Given this list of marker genes SLC31A2, PTGES, FAM171B, LYZ, SDCBP, UGCG, TES, KIF2A, SGK1, PALLD, TGOLN2, RHOB, ARL4C, MT1B, ALCAM, BMP2K, DNAJC10, RAB14, GRAMD1A, PNMA1, CTNNAL1, SERF2, CFL2, ISCA1, IQGAP2, UBE2E2, AOC3, FBXW2, GSTA4, NGRN, LMO2, ST6GAL1, GSN, RASSF8, HABP4, AFAP1L1, RNF38, UBQLN1, RNF41, PSMB7, TMEM268, RNASE4, MT1H, CELF2 (NCBI Gene Id 10659), SLC66A3, CCDC50, MYO5A, ITM2A, NEK6, H2BC5, OSER1, TRPS1, SON, SCML1, MT1E, POLE3, ALG2 (NCBI Gene Id 85365), RIMKLB, ISCU, MT1X, CNN3, BACE1, IFITM1, LINC00472, RCAN1, PSMD5, SOCS3, VCPKMT, PPP6C, DCBLD2 (discoidin, CUB and LCCL domain containing 2), TOX2, MT1L, RIC1, STXBP1, WHRN (whirlin), CCN3, CYBB, SETX, GNG10, TSC22D3 (TSC22 domain family member 3), SELENOP, DUSP22, C3AR1, CDK5RAP2, PSIP1, NFIL3, SCD5, MSANTD3, ZNF738, PRKCQ, CLIC4, ZFAND5, SLFN11, AP1S2, MAFB, ARMC8, PRPF4, FAM200B, SGCB, DAB2, FUBP3, ERP44, C9orf78, CD302, MS4A4A, NUDCD3, RAB21, PLAGL1 (NCBI Gene Id 5325), GABARAPL1, RCAN2, SET, LIG4, AK1, ALDH2, TGFBR1, ANXA5, CYBRD1, PER3, BEX2, MT2A, FAM120AOS, TGFB1, TMX4, DNAJB9, PMP22, PBX3, IARS1, RAD23B, MAP3K20, PTPDC1, TMOD1, GLIPR1, EVI2A, GNAQ, ZMAT1, MBNL1, TBC1D8, JADE1, DPYSL2, DDX3Y, ACSL4, here is a description of the gene set: We used gene expression profiling, mutation analyses of FGFR3 and TP53, and LOH analyses of chromosome 9 and the TP53 region on chromosome arm 17p, to molecularly characterize 75 Ta and T1 bladder carcinomas. We identified four major cellular processes related to cell cycle, protein synthesis, immune response, and extra cellular components that contribute to the expressional heterogeneity of early-stage urothelial cell carcinoma (UCC). Activating FGFR3 mutations were found at the highest frequency in G1 tumors (80%), and showed a strong correlation with FGFR3 expression. In contrast, G3 tumors displayed mutations in less than 10% of the cases and a low level of FGFR3 expression. Even though LOH on chromosome 9 was not associated with any specific expression pattern, our data indicate that loss of chromosome 9 is associated with tumor development rather than initiation. The combined analyses suggest the existence of two types of UCC tumors, one which is characterized by FGFR3 mutation or expression, high expression of protein synthesis genes, and low expression of cell cycle genes. Furthermore, the presented data underscore FGFR3 receptor involvement in urothelial cell transformation as the presence of FGFR3 mutations has a major impact on the global gene expression profile of bladder carcinomas. from publication Lindgren D, Liedberg F, Andersson A, Chebil G, Gudjonsson S, Borg A, Månsson W, Fioretos T, Höglund M (PMID 16532037) Genes whose expression profile is specific to Cluster IIa of urothelial cell carcinoma (UCC) tumors. Human Gene Set: LINDGREN_BLADDER_CANCER_CLUSTER_2A_DN studied in species Homo sapiens